Given this list of marker genes Prkaca, Prkacb, Cdk5, Ppp1ca, Prkar2b, Prkar1b (NCBI Gene Id 19085), Ppp2r5d, Ppp2r1b, here is a description of the gene set: Reactome Pathway: DARPP-32 events part of: Opioid Signalling electronically inferred by orthology from the curated human pathway This event has been computationally inferred from an event that has been demonstrated in another species.<p>The inference is based on the homology mapping from PANTHER. Briefly, reactions for which all involved PhysicalEntities (in input, output and catalyst) have a mapped orthologue/paralogue (for complexes at least 75% of components must have a mapping) are inferred to the other species. studied in species Mus musculus